Given this list of marker genes KMT5B, ATP1B2, PYM1, PHF24, PHF21A, IQSEC3, TAL1, UBAP1, ELF2, NIPAL4, CPSF7, IRF2, KCNG4, LAMC1, CD22, RIMS4, GNAO1, KCNB1, FBXL20, SIX1, CACNA1E, IFI44L, UBR2, LCE2A, SLC25A22, HIP1, SCRN1, ODF1, LUZP1, HDDC3, GPER1, ROCK2, CEACAM1, ATXN7L3, PDPR, ZFP3, ESRRG, CTDSP2, CHRNB4, PHF1, SLC7A8, PAXX, SLC6A11 (NCBI Gene Id 6538), PLEKHS1 (pleckstrin homology domain containing S1), LZTS1, IKZF3, CREB3L1, MECP2, PATZ1, NTRK2, GAL3ST3, CSTF2T, MYO9A, RBM22, STEAP4, SMURF1, NDE1, RAD1, VPS37C, UCP2, RUFY2, MOSMO, KPNA6, MSC, TNFAIP8L2, PXYLP1, CFAP70, GAB2, RNASE1, RAP1A, ZNF319, SZRD1, PATL1, TRIM27, TIAM1, ZBTB20, TAOK3, CFL1, CAPZA1, ZNRF1, AAK1, ZFYVE26, MBOAT2, RELL2, DOK3, PEAK1, FAM20B, AFAP1 (actin filament associated protein 1), WDTC1, FKBP5, AP2M1, NAV2, PSME3, C2orf49, CSTB, ZNF385A, AAMP, TNKS1BP1, EPHB2, ANKRD45 (NCBI Gene Id 339416), HIPK1, ZMYND11, ATP2B4, GLT6D1, HSPA12A, NKD1, EFHC1, MMP15, GTPBP3, DRD4, ANKRD44, RD3, ATP8A2, ADCY1, SUSD6, MTHFSD, NDUFA10, FBXO11, PHKA1, SLC37A2, SPTB, ELFN2, CELSR2, PLSCR3, SLC17A7, SMARCC2, KRTAP4-8, MICAL2, PLIN4, P3R3URF-PIK3R3, CD1C (CD1c molecule), BTRC, KLK5, PARP14, PAAF1, GLG1, POGZ, CLMN, SMARCD1, ATP2A1, TFPI (NCBI Gene Id 7035), STAG1 (NCBI Gene Id 10274), CFAP61, SPATA31D4, DGKK, MYO1D, HMGA1, FMOD (fibromodulin), MYD88, CORO2B, FGF12, ADRA1A, TPM4, SRF, SAMD4B, ST3GAL2, GJB1, MTF1, LY6G6C, TRDMT1, DKK3, WNT9B, HDAC1 (histone deacetylase 1), ZIC1, SORT1, DNAAF11, ZDHHC5, DHX58, HLA-E, UBTF, HOXC13, TEAD1 (NCBI Gene Id 8), SLC9A5, LINGO1, THAP11, TNFSF8, TRAM2, SMAP2, GSG1L, SMARCC1, MBD6, TM9SF1, PIK3R3, EPHA5, XKR4, ANKRD52, WDR82, PRKAG1, VPS53, NCSTN, NRF1, TNF, CRY2, OTP, CCDC157 (coiled-coil domain containing 157), FBXW11, DDX54 (DEAD-box helicase 54), HOXD11, HPS4, OTOF, ZER1, HEYL, SCAMP5, JPH4, TMEM178B, GDA (guanine deaminase), ZNF444, MBNL3, TMEM253, LSM5, SRPK1, CASTOR2, VCL (NCBI Gene Id 7414), RAB3C, NFIA, SRSF10, PRDM1, APBA1, CBX7 (chromobox 7), C11orf68, IGF1R, CCNT1, KAT7, MYADM, SLC19A2, GLYR1, TAF4, HTR1B, CSNK1G1, CDC42, KCNG3 (potassium voltage-gated channel modifier subfamily G member 3), MPZL2, ARID4A, RPRD1B, KCNN3, MEF2D, AMMECR1, SHANK1, RB1CC1, SRRD, SHROOM4, ITGA11, LASP1, SGPL1, YWHAE, CDK4, RXRB, FOSL2, SPHKAP, BCL9, AHCYL2, TBC1D13, PACS1, RNF122, SON, FAM3C, GAPDHS, DUSP10, PGAP4, DLK1, XYLT1, PNKD, MTCL2, PRKD3, PIANP, KDM7A, POU2AF1, FBXO41, CASQ1, SLC3A2, SPRY4, ILRUN, HCLS1, BAZ2A, SHISA6, MAP3K9, NKX3-1, KREMEN1, SDK1, STIM1, SLC8A1, AGO1, FBXO42, ADRB3, DISC1, PURG, TNPO2 (NCBI Gene Id 80048), BEND3, CCDC97, here is a description of the gene set: Genes predicted to be targets of miRBase v22 microRNA hsa-miR-5196-5p in miRDB v6.0 with MirTarget v4 prediction scores > 80 (high confidence targets). from publication Chen Y, Wang X (PMID 31504780) Human Gene Set: MIR5196_5P studied in species Homo sapiens